The following is a description of a gene set: A discontinuity of the skin exhibiting incomplete loss of the epidermis, a lesion that is moist, circumscribed, and usually depressed. studied in species Homo sapiens Human Gene Set: HP_SKIN_EROSION Skin erosion, and this is the list of marker genes: ZMPSTE24, ECM1, COL7A1, GNA11, LAMC2, DSP, KRT5, PPOX, LMNA, COL2A1 (collagen type II alpha 1 chain), LAMB3, CSTA, EPHB4, UROS, ITGB4, KRT1, KRT14, KRT10, KIT, PLEC, NAXE, TGM5, LAMA3, GATA1, RIPK4, ATP2C1 (NCBI Gene Id 612), ARL6IP6, UROD